The following is a description of a gene set: Inflammatory cytokines and their receptors modulated in brain tumors after treatment with an oncocytic virus, a potential anticancer therapy. from publication Kurozumi K, Hardcastle J, Thakur R, Yang M, Christoforidis G, Fulci G, Hochberg FH, Weissleder R, Carson W, Chiocca EA, Kaur B (PMID 18042934) Human Gene Set: KUROZUMI_RESPONSE_TO_ONCOCYTIC_VIRUS BACKGROUND: The tumor microenvironment is being increasingly recognized as an important determinant of tumor progression as well as of therapeutic response. We investigated oncolytic virus (OV) therapy-induced changes in tumor blood vessels and the impact of modulating tumor vasculature on the efficacy of oncolytic virus therapy. METHODS: Rat glioma cells (D74/HveC) were implanted intracranially in immune-competent rats. Seven days later, the rats (groups of 3-7 rats) were treated with oncolytic virus (hrR3), and, 3 days later, brains were harvested for evaluation. Some rats were treated with angiostatic cRGD peptide 4 days before oncolytic virus treatment. Some rats were treated with cyclophosphamide (CPA), an immunosuppressant, 2 days before oncolytic virus treatment. Changes in tumor vascular perfusion were evaluated by magnetic resonance imaging of live rats and by fluorescence microscopy of tumor sections from rats perfused with Texas red-conjugated lectin immediately before euthanasia. Leukocyte infiltration in tumors was evaluated by anti-CD45 immunohistochemistry, and the presence of oncolytic virus in tumors was evaluated by viral titration. Changes in cytokine gene expression in tumors were measured by quantitative real-time polymerase chain reaction-based microarrays. Survival was analyzed by the Kaplan-Meier method. All statistical tests were two-sided. RESULTS: Oncolytic virus treatment of experimental rat gliomas increased tumor vascular permeability, host leukocyte infiltration into tumors, and intratumoral expression of inflammatory cytokine genes, including interferon gamma (IFN-gamma). The increase in vascular permeability was suppressed in rats pretreated with cyclophosphamide. Compared with rats treated with hrR3 alone, rats pretreated with a single dose of cRGD peptide before hrR3 treatment had reduced tumor vascular permeability, leukocyte infiltration, and IFN-gamma protein levels (mean IFN-gamma level for hrR3 versus hrR3 + cRGD = 203 versus 65.6 microg/mg, difference = 137 microg/mg, 95% confidence interval = 72.7 to 202.9 microg/mg, P =.006); increased viral titers in tumor tissue; and longer median survival (21 days versus 17 days, P<.001). CONCLUSIONS: A single dose of angiostatic cRGD peptide treatment before oncolytic virus treatment enhanced the antitumor efficacy of oncolytic virus. species: Rattus norvegicus, and this is the list of marker genes: IL1R2, IL10RA (NCBI Gene Id 3587), IL11, XCR1, CCL3, IFNG, CCR4, IL6R, CXCL9, IL1B, CASP1 (NCBI Gene Id 834), CCL22, CCR5, ITGAD, CCL23, CCR7, IL18, LTA, IL2RB, CD40LG, IL13RA1, TNF, IL16, C3, IL6ST, CXCR2, CCL5, CCL7, CCR2, CCL2, SPP1, IL36RN, CXCR5, CXCL2, CCR6, CCR9, CCL20, CCR1, IL1A (interleukin 1 alpha), IL15, CXCL10, IL2RG, CXCR3, TNFRSF1B, LTB